Given this list of marker genes Rab3a (NCBI Gene Id 19339), Tspoap1, Ppfia3, Cplx1, Syt1, Ppfia2, Stx1a, Unc13b, Ppfia4, Syn1, Syn2, Syn3, Rims1, Slc18a2, Stxbp1, Vamp2 (vesicle-associated membrane protein 2), Ppfia1, Snap25, here is a description of the gene set: studied in species Mus musculus Serotonin Neurotransmitter Release Cycle Mouse Gene Set: REACTOME_SEROTONIN_NEUROTRANSMITTER_RELEASE_CYCLE